Given this list of marker genes Htr1b (5-hydroxytryptamine (serotonin) receptor 1B), Htr1a, Htr1f, Htr5a, Htr5b, here is a description of the gene set: Mouse Gene Set: GOMF_GI_O_COUPLED_SEROTONIN_RECEPTOR_ACTIVITY Combining with serotonin and transmitting the signal across the membrane by activation of the Gi/o subunit of an associated cytoplasmic heterotrimeric G protein complex. The Gi/o subunit subsequently inhibits adenylate cyclase and results in a decrease in cyclic AMP (cAMP) levels. studied in species Mus musculus